The following is a description of a gene set: from publication Konuma T, Nakamura S, Miyagi S, Negishi M, Chiba T, Oguro H, Yuan J, Mochizuki-Kashio M, Ichikawa H, Miyoshi H, Vidal M, Iwama A (PMID 21540074) species: Homo sapiens Each fraction of mouse hematopoietic cells was purified by cell sorting from bone marrow of 8-week-old C57BL/6 mice, and its gene expression was analyzed. Genes up-regulated in comparison of erythroblasts versus neutrophils. Human Gene Set: GSE27786_ERYTHROBLAST_VS_NEUTROPHIL_UP, and this is the list of marker genes: SLAMF6, NUP35, CYB5D2, CDIN1, CCNA2, VANGL2, LIX1L, CYB5R3, MYL4, DRG1, CP (ceruloplasmin), C2CD3, LUC7L, FAM83F, ZNRD2, KRTAP26-1, DCAF10, OGDH, MAP3K1, GPR89B, ZFR2, NME7, YTHDF2, BCKDK, CYP8B1, RFTN1, HRG, NUDC, RBM48, ASPHD1, CIAO1, SAAL1, TSSK3, PGRMC2, SLC35D1, DRC3, LUC7L3, EIF2B3, YBX3, EPN3, RPS7, TERT, AMMECR1, ZPBP2, POLR1C, DDHD1, FIRRM, CUL4A, SH3YL1, GHRHR, PTPA, WDR7, PPP1R1A, CCL28, PAX6, PRR11, LGI3, SPTSSB, FAM169A, FOXL1 (NCBI Gene Id 2300), CD5, GAL3ST4, LOXL3, RNF123, RAB3IL1, WRAP53, RNF39, KRT8, ELF4, KDM5D, CDK1, TRAK2, PRDX4, FNIP2, CPA1, LRRC56, DEK, FBXW4, TTC28, SAP130, LIPF, TNK1, NARS2, LSM12, RNMT, SASS6, TRIL, SOD1, SETDB2 (NCBI Gene Id 83852), APOBEC2, UQCR10, OSBPL3 (NCBI Gene Id 26031), SLURP1, UBE2S, PPP3CB, RTTN, PPP1R3C, CYP4F2, NUP155, DNM1, BCLAF1, DDX24, EEF1E1, TCIM, FAM133B, MARCHF5, SLC4A1, GRIA4, SKA3, TRIO (NCBI Gene Id 7204), B4GALT2, SNRNP25, RPL3, CCR5, ZFPM2, C1orf174 (chromosome 1 open reading frame 174), FAM227B, MOB2, TUBG2, BORCS5, TGIF1, SLC25A42, GSTCD, CFB, LMLN, MEMO1, NASP, ZMAT2 (zinc finger matrin-type 2), ARVCF, TNFRSF11B, RPAP2, PSMD12, SMPD4, TLK1 (tousled like kinase 1), VAX1, ABCA3, RENBP, ESF1, UBOX5, GAD1, STRA8, KIF4A, ACBD4, NECAP2, GOLT1A, PTAR1, BMPR1B, METTL27, CMA1, NUP50, KCNK5, SPINK4, DHX32, PRNP, RETSAT, MSS51, TCHP, ANLN, YIPF4, STRBP, SGSM3, PIP5K1B, EGR3, FBXO45, CAB39L, NUP43, DGCR8, DDX59, OR5D18, SMYD4, SLC43A3, CUL9 (NCBI Gene Id 23113), OLA1, WIPI2, RBMS2, CBX5, NSG2, HSPBAP1, KCNG4, TMEM125, CENPE, HERC6, NAA80, GUCY1A2, PRELID3A, RHBDF1, SLC22A14, OR2S2, TMEM60, SLC22A13, UNC45A, ME3, NMU, COLCA1, PCSK6, FLRT2, SRPX2, POLD3, CTNND1, DISP2